Given this list of marker genes Chd7, Dmd, Slc24a4, Ntrk1, Plxna3, Sall1, Plxna1, here is a description of the gene set: studied in species Mus musculus The process whose specific outcome is the progression of the olfactory nerve over time, from its formation to the mature structure. The olfactory nerve is a collection of sensory nerve rootlets that extend down from the olfactory bulb to the olfactory mucosa of the upper parts of the nasal cavity. This nerve conducts odor information to the brainstem. Mouse Gene Set: GOBP_OLFACTORY_NERVE_DEVELOPMENT